Given this list of marker genes Mkks, Amot, Lrrk2, Lrch1, Rap1gds1, Arl2, Rrp1b, Bbs4, Tmed2, Spry2, Gpsm1, Dab2ip, Gmip, Rcc2, Plxnb3, Spry1, Sh3bp4, Arfgef1, Rdx, Ttc8, Hras, Wnk1, Usp17le, here is a description of the gene set: Mouse Gene Set: GOBP_NEGATIVE_REGULATION_OF_GTPASE_ACTIVITY Any process that stops or reduces the rate of GTP hydrolysis by a GTPase. species: Mus musculus